Given this list of marker genes TSEN2, TSEN54, SLC2A1, FARS2, SEPSECS, KCNT1, DLAT, DEPDC5, CHRNA4, PRDM13 (NCBI Gene Id 59336), RHOBTB2, TSEN15, TBC1D24, CABP4, CHRNA2, CRH, PRRT2, CHRNB2, PNKD, TSEN34, here is a description of the gene set: A form of dystonia characterized by episodes of dystonia (often hemidystonia or generalized) lasting from minutes to hours. There are no dystonic symptoms between episodes. Human Gene Set: HP_PAROXYSMAL_DYSTONIA species: Homo sapiens Paroxysmal dystonia